The following is a description of a gene set: species: Homo sapiens Human Gene Set: GOBP_REGULATION_OF_TUMOR_NECROSIS_FACTOR_MEDIATED_SIGNALING_PATHWAY Any process that modulates the rate or extent of the tumor necrosis factor-mediated signaling pathway. The tumor necrosis factor-mediated signaling pathway is the series of molecular signals generated as a consequence of tumor necrosis factor binding to a cell surface receptor., and this is the list of marker genes: ADIPOQ, CYLD, GPS2, PPP2CB, CASP4, SYK, RFFL (ring finger and FYVE like domain containing E3 ubiquitin protein ligase), CLDN18, TANK, NKIRAS1, SPPL2B, TNFAIP3, CARD16, PYCARD, SPATA2, CPNE1, TMC8, XIAP, NR1H4, CASP1, IKBKB, CCDC3, PIAS3, SPPL2A, NOL3, PELI3, SPHK1, NLRP2B, RIPK1, MIB2, HSPA1A, PIAS4, PRKN, NKIRAS2, CASP8, SHARPIN, ZNF675, TRAF2, MIR1246, EXT1, ULK1, PYDC2, TAX1BP1, PTPN2, TRAIP, CARD8, HIPK1, MIR130A, GSTP1, MIR21, MIR152, MIR27B, TNFRSF11B, HSPA1B, UBE2K, ADAM17, APOA1, NAIP, MIR125B1, LAPTM5, TRIM32, ANXA4, NRDC (nardilysin convertase), H2BC11, GAS6, ADAM10, CDK5R1, MAPKAPK2, PYDC1, MMP8, BIRC7, DICER1, F2RL1, OTULIN, TNFRSF1A, MIR24-1